The following is a description of a gene set: species: Homo sapiens part of: Transcriptional regulation by the AP-2 (TFAP2) family of transcription factors Reactome Pathway: Activation of the TFAP2 (AP-2) family of transcription factors The helix-span-helix motif and the basic region of TFAP2 (AP-2) transcription factor family members TFAP2A, TFAP2B, TFAP2C, TFAP2D and TFAP2E enable dimerization and DNA binding. AP-2 dimers bind palindromic GC-rich DNA response elements that match the consensus sequence 5'-GCCNNNGGC-3'. Most of the AP-2 binding sites slightly differ from the consensus, and individual AP-2 family members may differ in their binding site preferences. Transcriptional co-factors from the CITED family interact with the helix-span-helix (HSH) domain of TFAP2 (AP-2) family of transcription factors and recruit transcription co-activators EP300 (p300) and CREBBP (CBP) to TFAP2-bound DNA elements. CITED2 shows the highest affinity for TFAP2 proteins, followed by CITED4, while CITED1 interacts with TFAP2s with a very low affinity. Mouse embryos defective for CITED2 exhibit neural crest defects, cardiac malformations and adrenal agenesis, which can at least in part be attributed to a defective Tfap2 transactivation. DNA binding and transcriptional activity of TFAP2B homodimers is increased by binding to YEATS4 (GAS41)., and this is the list of marker genes: WWOX, TFAP2A, TFAP2B, CITED4, TFAP2E, EP300, CREBBP, TFAP2D, YEATS4, CITED2, TFAP2C, CITED1